The following is a description of a gene set: Mouse Gene Set: GOBP_REGULATION_OF_TOLL_LIKE_RECEPTOR_SIGNALING_PATHWAY Any process that modulates the frequency, rate, or extent of toll-like receptor signaling pathway. species: Mus musculus, and this is the list of marker genes: Lrrc14, App, Trim30a, Rnf115, Irf7, Gfi1, Esr1, Lgr4, Pik3ap1, Otud4, S100a9, Nfkbil1, Ccdc134, Tyro3, Mfhas1, Gpr108, Gps2, S100a8, Cd300a, Nlrp6, Irf4, Lrch4, Cd300lf, Smpdl3b, Arrb2, Pdpk1, Cactin, Ywhae (NCBI Gene Id 22627), Cd36 (NCBI Gene Id 12491), Irf1, Irak3, Tasl, Ptgs2os, Gdi1, Sarm1